The following is a description of a gene set: We identified three separate clusters (CL) of endothelial cells (CL7, CL9, CL16) expressing markers associated with lymph and blood vascular system (such as PECAM1, CD34, CTGF), but also associated with remodeling and inflammatory response (such as TXNIP, ANGPT2) (Fig. 3a-d). The DEGs of CL7 (such as CCL14, SOCS3, EGFL7) and CL16 (such as CCL21, TFF3) are linked to angiogenesis and lymphatics, respectively, while DEGs of CL9 (TM4SF1, NMMT) were more related to regulation of apoptosis (Fig. 3c, d). Human Gene Set: FAN_OVARY_CL16_LYMPHATIC_ENDOTHELIAL_CELL species: Homo sapiens from publication Fan X, Bialecka M, Moustakas I, Lam E, Torrens-Juaneda V, Borggreven NV, Trouw L, Louwe LA, Pilgram GSK, Mei H, van der Westerlaken L, Chuva de Sousa Lopes SM (PMID 31320652), and this is the list of marker genes: DIPK2B, ITM2B, LAMA4, ELK3, TM4SF18, SCN3B, HLA-B, ENG, MALAT1, APOD, TMEM123, NTS, STOM, DNAJC11, TIMP3, MTUS1, FXYD6, DUSP6, PFN1, ADD3, LIMS1, NKTR, H1-0, NFIA, TIE1, XIST, MAP1B, POLR2L, CALCRL, PROX1, FABP5, FXYD5, TFF3, DONSON, SHC1, CAVIN2, BCAP29, CD63, YWHAH, CD9, PTPRE, S100A16, APLP2, TGFBR2, RAB11A, PSAP, MYL12A (myosin light chain 12A), CNTNAP3B (contactin associated protein family member 3B), ATRAID, TNFSF10, ARL6IP1, EXOC1, SDF4, LAMP1, HMGN3 (NCBI Gene Id 9324), HEXB, VWF, B2M (NCBI Gene Id 567), NUCB1, RSRP1, ZFYVE21, NEAT1, C6orf141, HLA-C, LGALS3, GADD45B, GRN (NCBI Gene Id 2896), TFPI, TM4SF1, BCAP31, NORAD, AKAP12, MT-ND4L, ARL4A, DOCK5, TMEM50A, DEPP1, CLU, VGLL4, ARPC1B, TSPAN5, SMTN (smoothelin), PPP1R2, JUNB, FSCN1, CD59, S100A6, CYB5R3, PDPN, OS9, SELENOP, CALM1, TSPAN4, DAD1, LMAN2, UGP2, FN1, LRPAP1, RHOC, KLF6, SMAD1, SERPING1, TPM3, CTSD, PRCP (prolylcarboxypeptidase), IER2, STMN1, PECAM1, ATP5F1E, IGFBP4, MYL12B, SH3BGRL3, GIMAP4, DDX17 (NCBI Gene Id 10521), EGFL7 (EGF like domain multiple 7), SNX2, LOX, MT-CO1, CTHRC1, MYCT1 (MYC target 1), CCND1, MARCKS (NCBI Gene Id 4082), LDB2, RAMP2, NFIB, JUN, N4BP2L2, CEBPD, PTX3, ANXA5, SYPL1, ATP6AP2, A2M, TMEM255B, CDH5, MT-CYB, S100A10, NTAN1, ALDH1A1, MT-ND5, GMFG, NDUFS7, CLDN5, IFITM3, PROCR, MAN1A1, REEP5, REEP3, FKBP1A, GYPC, PIM3, EFEMP1, TMBIM6, PPIC, HLA-A, APP, CLEC14A, TRAPPC1, GUK1, OCIAD1, MMP2, ACTR2 (actin related protein 2), FDPS, RASGRP3, KLF4, IL6ST, EFNA1, SPTBN1, GIMAP7, HSPB1, LEPROT, PPFIBP1, PRXL2A, LAMP2, CCN1, GFUS, NPC2, FOSB, TCF4, GNAS, DUSP1, WFS1, EPSTI1, LAPTM5, ARHGAP29, GNG11, ADCY4, TMEM59, NNMT, ANGPT2, DDX5, RTN4, CCL21, TSPO, KLF10, PET100, KCTD12, MGST2, FLT4, CRBN, CRIP2, ARL2, GJA1, CFI, TUBA1A, NR2F2, MMRN1, ANXA2, HLA-E, ADM, SLC38A1, COMT, FABP4, FOS, HYAL2, ABI3BP, PTMS, REXO2, MFAP2, DEGS1, KRTCAP2, CTSL, SPSB3, ODF2L, CAVIN1, SBDS, IGFBP7, PRSS23, FCGRT, CD151, NRP2, TXNIP